Given this list of marker genes Rest, Hsd17b3, Ggcx, Hsd17b1, Creb1, Cmtm2a, Srd5a2, Clcn2, Scp2, Stard3, Bglap2, Prkg1, Dkk3, Akr1c18, H6pd, Dgkq, Egr1, Gprc6a, Dab2, Wnt4, Ppargc1a, Cyp19a1, Bmp5 (bone morphogenetic protein 5), Dkkl1, Cacna1h, Bmp6, Cyp11b2, Star, Cyp11b1, Bmp2, Bglap, Inhba, here is a description of the gene set: Mouse Gene Set: GOBP_OLEFINIC_COMPOUND_BIOSYNTHETIC_PROCESS The chemical reactions and pathways resulting in the formation of an olefinic compound, any compound which contains a carbon-carbon double bond (aka C=C). species: Mus musculus